The following is a description of a gene set: The cell cycle transition where a cell leaves M phase and enters a new G1 phase. M phase is the part of the mitotic cell cycle during which mitosis and cytokinesis take place. species: Mus musculus Mouse Gene Set: GOBP_EXIT_FROM_MITOSIS, and this is the list of marker genes: Zw10, Tgfb1, Ube2c, Rpl24, Nfia, Chmp7, Cdc14a, Ctdp1, Eps8, Rgcc, Cdkn1b, Ube2srt, Mir124a-1, Mir124a-2, Cdkn1c, Ppp2r2d, Chmp2a, Ube2s, Npm2, Chmp4b, Neurog1, Nfib, Mad2l1bp, Phb2, Mir124a-3, Clasp2 (CLIP associating protein 2), Nfix, Clasp1, Birc5, Cdca5, Cdc14b, Spast (spastin)